The following is a description of a gene set: species: Homo sapiens Human Gene Set: GOBP_AMYLOID_FIBRIL_FORMATION The generation of amyloid fibrils, insoluble fibrous protein aggregates exhibiting beta sheet structure, from proteins., and this is the list of marker genes: TARDBP, RIPK3, PFDN1, FUS, SIAH2, CDSN, TREM2, PFDN5, MDM2, APOE, GSN, MIR31, PFDN2, APP, CAMP, EMD, MAPT, LDLR, CDKN2A, VBP1, PFDN6, NUP153, SERF1A, RIPK1, B2M, IAPP, CD36, SNCA, NAT8B, FURIN, CHRNA7, SERF1B, USP8, CLU, PFDN4, HSPG2, FKBP1A, NAT8 (N-acetyltransferase 8 (putative)), CRYAB, PSEN1, SIAH1, VHL, PRKN, BACE1, USP9X